Given this list of marker genes TCOF1, JAK3, SALL1, CCNQ (cyclin Q, NCBI Gene Id 92002), POLR1C, DACT1, POLR1D, FREM1, MKKS, TCTN3, PI4KA, DDB1, RECQL4, KIF7, LONP1, RNU12, POLR1B, SALL4, UBR1, MNX1, SPINT2, IL10RB, here is a description of the gene set: Rectovaginal fistula The presence of a fistula between the vagina and the rectum. Human Gene Set: HP_RECTOVAGINAL_FISTULA studied in species Homo sapiens